The following is a description of a gene set: species: Mus musculus The chemical reactions and pathways involving cryptic unstable transcripts (CUTs), which are transcribed from intergenic regions. Many intergenic regions are heavily transcribed, but the transcripts are rarely detected due to rapid degradation by the nuclear exosome. Mouse Gene Set: GOBP_CUT_METABOLIC_PROCESS, and this is the list of marker genes: Dis3, Exosc2, Exosc10, Zcchc7, Exosc3